The following is a description of a gene set: Reactome Pathway: Removal of the Flap Intermediate part of: Processive synthesis on the lagging strand Two endonucleases, Dna2 and flap endonuclease 1 (FEN-1), are responsible for resolving the nascent flap structure. The Dna2 endonuclease/helicase in yeast is a monomer of approximately 172 kDa. Human FEN-1 is a single polypeptide of approximately 42 kDa. Replication Protein A regulates the switching of endonucleases during the removal of the displaced flap (Tsurimoto et al.1991). species: Homo sapiens, and this is the list of marker genes: POLD3, RPA3, PRIM1, POLA2, POLD4, FEN1, DNA2, RPA1, PRIM2, POLA1, PCNA (proliferating cell nuclear antigen), POLD2, RPA2, POLD1